Given this list of marker genes Gata4, Nfix, Smad4, Tbx3, Chd7, Ptpn11, Tbx20, Bmp2, Eng, Tbx2, Rbpj, Has2, Foxn4, here is a description of the gene set: Mouse Gene Set: GOBP_ATRIOVENTRICULAR_CANAL_DEVELOPMENT species: Mus musculus The progression of the atrioventricular canal over time, from its formation to the mature structure. The atrioventricular canal is the part of the heart connecting the atrium to the cardiac ventricle.